The following is a description of a gene set: Human Gene Set: GOMF_CORECEPTOR_ACTIVITY studied in species Homo sapiens Combining with an extracellular or intracellular messenger, and in cooperation with a nearby primary receptor, initiating a change in cell activity., and this is the list of marker genes: RECK, RYK, CXCR4, IL2RG, ZP2, ROR1, ACKR3, ITGA4, NRP1, IL12RB1, ROR2, GPC4, CD4, IL10RB, LRP6, ERBB2 (erb-b2 receptor tyrosine kinase 2), IL12RB2, LRP5, ITGB1, RAMP1, PTK7, CCR5, RGMB, KDR, CD8B2, HJV, FCRL1, LRP4, IL18RAP, ACVR2A, LY96, GPR15, CD80 (CD80 molecule), TMIGD2, RGMA, CCR8, NECTIN2, LILRA4, TGFBR3, RAMP3, ENG, ITGAV (NCBI Gene Id 7449), CSF2RB, CD28, FCRL5, IL1RAP, LBP, CSPG4, RAMP2, CXCR6 (NCBI Gene Id 10663), NECTIN1, CD86, CD8B, IL2RB, CD8A, NGFR, ITGB3, IL17RC, IL6ST, GPC6, CRLF2